The following is a description of a gene set: The series of events required for an organism to receive a gustatory stimulus, convert it to a molecular signal, and recognize and characterize the signal. Gustation involves the direct detection of chemical composition, usually through contact with chemoreceptor cells. This is a neurological process. studied in species Homo sapiens Human Gene Set: GOBP_SENSORY_PERCEPTION_OF_TASTE, and this is the list of marker genes: ITPR3, RTP5, TAS2R1, TAS2R7, TAS1R2, RTP2, TAS2R14, REEP2, TAS1R1, FFAR4, PKD1L3, GNG13, TAS2R38, SCNN1D, TAS2R50, CALHM1, TAS2R40, CA6, TAS2R10, GNAT3, TAS2R9, TAS2R30, P2RX3, GNAT2, PIP, CST4, TAS2R45, CST1, SCNN1B, ASIC2, LCN1, TAS2R19, TAS2R31, TAS2R46, LPO, TAS2R39, GNB1, TAS1R3, TAS2R43, TAS2R41, SCNN1G, AZGP1, WNT10B, TAS2R13, TAS2R5, ASIC3, TAS2R16, SCNN1A, P2RX2, RGS21, TRPV1, TAS2R8, RTP1, PKD2L1, PLCB2, TAS2R3, TAS2R60 (taste 2 receptor member 60), PIGR (polymeric immunoglobulin receptor), LEF1, GNAT1, TAS2R4 (taste 2 receptor member 4), ASIC1, CALHM3, RTP3, RTP4, CD36, CST2, TAS2R42, TAS2R20